Given this list of marker genes UBL3, CEP68 (NCBI Gene Id 23177), ZFHX2, AMT, IRS4, S1PR1, SARAF, TRAM2, LPAR3, SNRK, AKAP9, SGSM2, PRKCZ, CMC4, ZNF91, RHOT2, REC8, DMTF1 (cyclin D binding myb like transcription factor 1), TTC17, DELE1, A4GALT, RAB25 (RAB25, member RAS oncogene family), CAMKV, NCK2, PHC1, ZNF768, PPOX, PPP1R12B, ZNF83, SNHG17, CAPN3, IFI44, CREBBP, BICRAL, CHKB, SORBS3 (NCBI Gene Id 10174), RGS12, RSAD1, USP34, APOA4, RPS6, ARL4D, ELANE, MYCBP2, P2RX6, SPG7, TRIB2, LTBP3, FAIM2, SLC9A8, LDAF1, ARHGEF1, KCNC3, ATP8A1, FLI1, PARP6, ZFP36L1, DDX5, HOOK2, BIN2, CTSL, IP6K2, TSPYL2, KLHL20, NDRG2, KAT6B, SPSB3, MFGE8, CIRBP, SIRPG, TTC3, TTN, MCF2L, TMEM123, ZNF767P, SNHG32, OSER1, CLUHP3, SUN1, DLG1, KLHL36, PAN2, ZFC3H1, RHOH, NKTR, CFAP410, SF1, TRAPPC10, PTP4A3, SNX6, TPCN1, APP, LITAF, KCND1, ANKH, FAM193B, C11orf21, ERP29, SRSF5, CSGALNACT1, DUSP22, BDKRB2, RAB40B, VAT1, CDC25B, PXN, WWP1, SMPD1, ITPR3, BIN1, NLRP1 (NCBI Gene Id 82286), NAP1L1, LYPD3, TCEAL4, COQ8A, TSPAN32, NIPAL3, SYNJ2BP, USP19, MAP4K2, ERGIC3, FBXO21, LLGL2 (LLGL scribble cell polarity complex component 2), SAMHD1, LRCH4, VTCN1, KAT8, OGA, VPS13D, MN1, STX16, UVRAG, DGKD, KLF9, EIF3F, TP53TG5, SF3B1, ZNF710, BANP, SH2B1 (NCBI Gene Id 25970), RCOR3, ERBIN, NPIPA1, MAP3K1, ITPKB, ISYNA1, PCBP2, CCNT2, LAIR1, PHKA2 (phosphorylase kinase regulatory subunit alpha 2), ATXN7L3B, IQSEC1, RABGAP1, STMN3, R3HDM2, USP4, GFRA3, LMBR1L, STAT5B, AP2A2, CUL9, TLE5, INTS1, STIM1, MAP2K5, SNPH, NFATC1, KLF3, JADE2, PINK1, LZTFL1, COX4I1, ZBTB22 (NCBI Gene Id 9278), KAT6A, IL11RA, RPL23AP32, ATP1A1, NPC2, PARP16, KLF7, ECHDC2, RPL3, LRIG2 (leucine rich repeats and immunoglobulin like domains 2), PNISR, KIT, ST3GAL5, SIPA1L3, MZF1, ARFGAP2, LSR, PPFIBP2 (PPFIA binding protein 2), MYO15B, GP1BA, AP1G2, TMEM8B, HEBP1, OSBPL7, AZU1, MSL1, here is a description of the gene set: from publication Abbas AR, Baldwin D, Ma Y, Ouyang W, Gurney A, Martin F, Fong S, van Lookeren Campagne M, Godowski P, Williams PM, Chan AC, Clark HF (PMID 15789058) species: Homo sapiens Genes up-regulated in comparison of naive CD4 T cells versus stimulated CD4 Th2 cells at 12 h. Immune cell-specific expression is one indication of the importance of a gene's role in the immune response. In order to identify such patterns, we set out to broadly profile gene expression in a variety of immune cells. Human Gene Set: GSE22886_NAIVE_CD4_TCELL_VS_12H_ACT_TH2_UP